Given this list of marker genes PAX8, SOX9, WNT4, CALB1, AQP1, PKD2, PAX2, OSR1, YAP1, LGR4, PKD1, LIF, SOX8, HES5, ACAT1, POU3F3, STAT1, WNT7B, HES1, WWTR1, SLC22A1 (solute carrier family 22 member 1), SLC22A6, UMOD, WNT9B, here is a description of the gene set: The progression of a metanephric tubule over time, from its initial formation to the mature structure. A metanephric tubule is an epithelial tube that is part of the metanephros. Human Gene Set: GOBP_METANEPHRIC_TUBULE_DEVELOPMENT species: Homo sapiens